The following is a description of a gene set: Reactome Pathway: Metabolism of serotonin This event has been computationally inferred from an event that has been demonstrated in another species.<p>The inference is based on the homology mapping from PANTHER. Briefly, reactions for which all involved PhysicalEntities (in input, output and catalyst) have a mapped orthologue/paralogue (for complexes at least 75% of components must have a mapping) are inferred to the other species. part of: Serotonin clearance from the synaptic cleft species: Mus musculus electronically inferred by orthology from the curated human pathway, and this is the list of marker genes: Aldh2